Given this list of marker genes EGFR, NRG4, NRG1, EGF, BTC, ERBB3, MEMO1, EREG, NRG3, HBEGF, ERBB2 (NCBI Gene Id 2064), DIAPH1, NRG2, RHOA, ERBB4, here is a description of the gene set: studied in species Homo sapiens Human Gene Set: REACTOME_ERBB2_REGULATES_CELL_MOTILITY ERBB2 Regulates Cell Motility